The following is a description of a gene set: Human Gene Set: GOBP_RECEPTOR_DIFFUSION_TRAPPING The process by which a membrane receptor, diffusing freely within the plasma membeane, becomes trapped in some plasma membrane region. This can happen when a receptor bind, directly or indirectly, to some component of the underlying matrix. species: Homo sapiens, and this is the list of marker genes: CACNG8, CACNG7, SLC12A5, RDX, SHISA6, ZDHHC2, CACNG2 (calcium voltage-gated channel auxiliary subunit gamma 2), TSPAN9, CACNG5, ITGB3, CACNG3, CACNG4